The following is a description of a gene set: studied in species Homo sapiens Human Gene Set: GOMF_CARBON_SULFUR_LYASE_ACTIVITY Catalysis of the elimination of hydrogen sulfide or substituted H2S., and this is the list of marker genes: MGST2, ALOX5AP, CENPVL2, LTC4S, CENPVL3, GLO1, MGST3, CTH, CENPV, GSTM4, CENPVL1, KYAT1, HCCS, ACCS, SCLY, KYAT3